The following is a description of a gene set: Cessation of life at the age of 16 years or later. Death in adulthood species: Homo sapiens Human Gene Set: HP_DEATH_IN_ADULTHOOD, and this is the list of marker genes: APP, DNAJC30, TNNI3, GTF2IRD2, GTF2I, TBL2, MYH6, TMEM270, LIMK1, PIK3CA, TGFBR2, TYMP, LAMC2, ZMPSTE24, RFC2, PMS1, SCN4A (NCBI Gene Id 6329), EPCAM, NCF1, PMS2, MLH1, VPS4A, BAZ1B, EIF4H, POLR3A, CLIP2, BCS1L, POLR3B, ACTB, DSP, CST3, BUD23, GTF2IRD1, VPS37D, STX1A, KRAS, ELN, MYH7, FKBP6, POLG, METTL27, MSH6, MSH2